The following is a description of a gene set: Cell types are named using anatomical and functional mnemonics prefixed by 'm' or'h' to indicate mouse and human respectively: OMTN, oculomotor and trochlear nucleus; Sert, serotonergic; NbM, medial neuroblast; NbDA, neuroblast dopaminergic; DA0-2, dopaminergic neurons; RN, red nucleus; Gaba1-2, GABAergic neurons; mNbL1-2, lateral neuroblasts; NbML1-5, mediolateral neuroblasts; NProg, neuronal progenitor; Prog, progenitor medial floorplate (FPM), lateral floorplate (FPL), midline (M), basal plate (BP); Rgl1-3, radial glia-like cells; Mgl, microglia; Endo, endothelial cells; Peric, pericytes; Epend, ependymal; OPC, oligodendrocyte precursor cells. from publication La Manno G, Gyllborg D, Codeluppi S, Nishimura K, Salto C, Zeisel A, Borm LE, Stott SRW, Toledo EM, Villaescusa JC, Lönnerberg P, Ryge J, Barker RA, Arenas E, Linnarsson S (PMID 27716510) studied in species Homo sapiens Human Gene Set: MANNO_MIDBRAIN_NEUROTYPES_HNBM, and this is the list of marker genes: TSIX, CD24, NCAN, NOVA1, ST6GAL1, RGS4, SLITRK1, PGBD5, GRIK2, MSANTD3-TMEFF1, MAP3K9, RPS19, CELF3, PEX5L, ST8SIA3, FGF9, LRRTM4 (NCBI Gene Id 80059), POU3F1, SSBP3, PTPRO (protein tyrosine phosphatase receptor type O), EN2, ELAVL3, RUNDC3A, MLLT11, NCAM1, BSN, NFASC, KLC1, MTUS2, SOX11, POLB, PHACTR3, LMOD3, SYT7, GSE1, CLVS2, DUSP26, MAPK6, MAPK8, SLC22A15, GNG3, MCF2L, GAP43, MIR671, CDC42EP3, STMN4, CRMP1, THSD7A, VWDE, ST6GAL2, CADPS, LPAR2, PBX3, MEGF6, ZHX1, TMEM169, TUBB2B, SVIP, SCN3A, DSCAML1, PCSK2, TAGLN3, SCG3, MAP2, IGFBPL1, LRRC55, PRKX, CD2, TES, RND3 (Rho family GTPase 3), ATCAY, ZSCAN9, OTP, LRRTM2, ZFTA, RUFY3, CBFA2T2, ST18, AFAP1, LZTS1, EFS, CELSR3, AUTS2, EPB41, PDE4DIP, SOX4, DPYSL4, SLC4A8, CNR1, PLEKHA6, TMEM86B, NEUROD1, ZBTB46, SLC38A1, DCX, MAML3, STMN2, NRSN1, PCDH8, NEDD4L, MIAT, PAPPA (NCBI Gene Id 5069), PRKAR2B, SEZ6, SOBP, FNDC5, ATL1, SCG5, CRB1, TOX3, ATP1A3, PCDHGC3, GFRA1, TMEM121B, TLCD3B, RAB3C, ROBO1, KLHL35, ELAVL4, MACO1, ASIC3, SKIDA1, MIR124-2HG, LCOR, ZNF737, JPT1, ZNF117, PIP4P2, TAMALIN, EBF3, NFIX, ADA2, PRDM8, RBFOX3, MYT1, PTPRG, MAB21L1, PLXNA3, RGMB, VAV3, NXPH4, DCLK1 (doublecortin like kinase 1), FMN2, TRPM8, SHF, NHLH2, ROBO3, SRL, KCNQ3, VASH2, DCC, CSMD3, ZNF529-AS1, SCHIP1, BRSK2, GRIN3A, ACVR2B, SNAP25, MDGA1, RCOR2, NEUROD6, GDPD1, TMEM163, BZW2, EDIL3, RBFOX2, ZNF33A, XKR4, INHBA-AS1, SMPD3, PPP1R17, GAS2, INSM1, PAK3, BHLHE22 (NCBI Gene Id 27319), NKAIN1, ZNF738, CHML, ELAVL2, NEUROD4, DPYSL3, UBE2QL1 (ubiquitin conjugating enzyme E2 QL1), STXBP5, CLVS1, TMSB15A, SHOX2, KIF21B, MIR7-3, SEMA6C, NEUROG2, CALB2, RELN (NCBI Gene Id 5649), GNG2, FOXA1, SRRM4, MTCL3, DLL3, BCL11A, AP3B2 (NCBI Gene Id 8120), INA, TSPAN11, FOXP2, CRACD, VWA5A, C1orf35, KIF5C, DIS3L2, XIST, RHOU, GDPD3, PDP1, TSPAN13, AJAP1, HEPACAM2, H2AC25, GPC2, DMRTA2, RALGDS, PITX2, POU6F1, SOX5, NHLH1, TUBA1A, HS3ST1 (heparan sulfate-glucosamine 3-sulfotransferase 1), ST8SIA2, SEC31B, TUBB4A, RMST, SLC46A3, PKP2, CASD1, FOXA2, MAP6, APOL4, CD27-AS1, SCN8A, CEP15, DNAJB5, PCBP4, ATOSA (NCBI Gene Id 56204), RAP1GAP2, CYRIA, ADAMTS5, PHF21B, POU3F2, CNTN2, MICAL1, MIB1, SCRT2, KCNH8, EBF2, PHLDA1 (NCBI Gene Id 22822), ANK2, SSTR2, TUBB3, NAPB, CCBE1, GABARAPL1, GPM6A, NAV1, CCSAP, NRN1, SLC17A6, GREM2, SAMD5, CTNNA2, ASXL3, CADM1, RAB11FIP4, GRM8, CHN2, AMER2, NNAT, ZMAT4, TRIM36, ZFHX4, PHTF1, ZNF878, ARK2C, CXADR, SV2B, TERF2IP, ZNF195, SMIM18 (small integral membrane protein 18), EBF1, STMN1, TMTC4, DPYSL5, MAP1B, ADGRG1, POU2F2, SBK1, NSG1, GDAP1L1, CSRNP3